The following is a description of a gene set: Mouse Gene Set: GOBP_SEX_CHROMOSOME_DOSAGE_COMPENSATION studied in species Mus musculus Compensating for the variation in the unpaired sex chromosome:autosome chromosome ratios between sexes by activation or inactivation of genes on one or both of the sex chromosomes., and this is the list of marker genes: Zfy2, Ythdc1, Macroh2a2, Hnrnpk, Smchd1, Macroh2a1, Pcgf5, Lbr, Xist, Rlim, Jpx, Upf3b, Prdm14, Cdyl, Brca1, Suz12, Ftx, Upf3a, Upf1, Ncor2, Tsix, Jarid2, Exosc10, Spen, Eif1 (eukaryotic translation initiation factor 1), Ctcf, Rbm15b, Pcgf3, Lrif1, Rbm15 (NCBI Gene Id 229700), Mettl3, Hnrnpu (NCBI Gene Id 98724), Kat8, Hdac3